The following is a description of a gene set: Abnormality of vitamin B metabolism Human Gene Set: HP_ABNORMALITY_OF_VITAMIN_B_METABOLISM studied in species Homo sapiens, and this is the list of marker genes: AMN, DHFR, CCND1, ZNF699, PNPLA8, MMACHC, CUBN, RNU4-2, SLC19A1, MMAA, HLA-DQB1, GUCY2C, DLAT, TCN2, ACSF3, CBLIF, ABCD1, TTR, ALDH4A1, FAS, PRDX1, MTR, HCFC1, SIM1, FASLG (Fas ligand), SUCLG1, SLC46A1, SUCLA2, HLA-DQA1, SPTBN1, OTUD5, ABCD4, MTRR, MTHFD1, RNF13, FTCD, CD320 (NCBI Gene Id 51293), MMADHC, GRM7, CASP10, MMUT (NCBI Gene Id 4594), MMAB, LMBRD1, ALDH6A1, SLC52A1